The following is a description of a gene set: Human Gene Set: LEIN_LOCALIZED_TO_DISTAL_AND_PROXIMAL_DENDRITES Transcripts showing subcellular localization to both distal and proximal dendrites in the adult mouse brain. Molecular approaches to understanding the functional circuitry of the nervous system promise new insights into the relationship between genes, brain and behaviour. The cellular diversity of the brain necessitates a cellular resolution approach towards understanding the functional genomics of the nervous system. We describe here an anatomically comprehensive digital atlas containing the expression patterns of approximately genes in the adult mouse brain. Data were generated using automated high-throughput procedures for in situ hybridization and data acquisition, and are publicly accessible online. Newly developed image-based informatics tools allow global genome-scale structural analysis and cross-correlation, as well as identification of regionally enriched genes. Unbiased fine-resolution analysis has identified highly specific cellular markers as well as extensive evidence of cellular heterogeneity not evident in classical neuroanatomical atlases. This highly standardized atlas provides an open, primary data resource for a wide variety of further studies concerning brain organization and function. species: Mus musculus from publication Lein ES, Hawrylycz MJ, Ao N, Ayres M, Bensinger A, Bernard A, Boe AF, Boguski MS, Brockway KS, Byrnes EJ, Chen L, Chen L, Chen TM, Chin MC, Chong J, Crook BE, Czaplinska A, Dang CN, Datta S, Dee NR, Desaki AL, Desta T, Diep E, Dolbeare TA, Donelan MJ, Dong HW, Dougherty JG, Duncan BJ, Ebbert AJ, Eichele G, Estin LK, Faber C, Facer BA, Fields R, Fischer SR, Fliss TP, Frensley C, Gates SN, Glattfelder KJ, Halverson KR, Hart MR, Hohmann JG, Howell MP, Jeung DP, Johnson RA, Karr PT, Kawal R, Kidney JM, Knapik RH, Kuan CL, Lake JH, Laramee AR, Larsen KD, Lau C, Lemon TA, Liang AJ, Liu Y, Luong LT, Michaels J, Morgan JJ, Morgan RJ, Mortrud MT, Mosqueda NF, Ng LL, Ng R, Orta GJ, Overly CC, Pak TH, Parry SE, Pathak SD, Pearson OC, Puchalski RB, Riley ZL, Rockett HR, Rowland SA, Royall JJ, Ruiz MJ, Sarno NR, Schaffnit K, Shapovalova NV, Sivisay T, Slaughterbeck CR, Smith SC, Smith KA, Smith BI, Sodt AJ, Stewart NN, Stumpf KR, Sunkin SM, Sutram M, Tam A, Teemer CD, Thaller C, Thompson CL, Varnam LR, Visel A, Whitlock RM, Wohnoutka PE, Wolkey CK, Wong VY, Wood M, Yaylaoglu MB, Young RC, Youngstrom BL, Yuan XF, Zhang B, Zwingman TA, Jones AR (PMID 17151600), and this is the list of marker genes: SBK1, DLG4, CPE (NCBI Gene Id 1363), ITPR1, EPB41L1, CAMK2A, PRXL2A, BTBD3, KIF5A, BOK, ADCY1, LPAR1, SOWAHA, RGS8, PSD, MT-ATP6, HPCAL4, PPP1R9B